The following is a description of a gene set: studied in species Mus musculus Mouse Gene Set: WP_GPCRS_ODORANT GPCRs, odorant, and this is the list of marker genes: Tas2r125, Brs3, Gpr158, Or5p76, Gpr107, Gpr108, Gpr31b, Mrgpra1, Mrgprb8, Cmklr2, Tas2r107, Gpr182, Gpr153, Vmn1r42, Or8g17, Gpr34, Vmn1r51, Taar7e, Tas2r117, Gpr87, Or10d1b, Tas1r2, Gpr139, Gpr150, Or7a40, Vmn1r48, Tas2r138, Tas2r102, Tas2r135, Vmn2r-ps54, Gpr82, Mrgprb3, Tpra1, Tas2r124, Or5p4, Opn1sw, Gpr162 (NCBI Gene Id 14788), Or9s13, Mrgprf, Taar5, Tas2r120, Gpr22, Tas2r143, Tas2r106, Mrgprb5 (NCBI Gene Id 404239), Or6b9 (NCBI Gene Id 258349), Gpr37l1, Mrgprh, Or5t17, Gpr142, Or3a10, Lgr5, Oprl1, Or7d11, Or10n1, Mrgpra4, Adgra2, Tas1r3, Gpr20, Gpr101, Gpr61, Hcar1, Or8a1b, Tas2r114, Or10p22, Rho, Gpr4, Or4b13, Vmn2r1, Gpr55, Gpr180, Or2a7, Gpr160, Or2b6, Vmn1r53, Mrgpre, Taar4, Gpr63, Or5g26, Adgrg5, Gpr152, Gpr88, Or5p79, Or1j1, Gpr27, Or5j3, Gpr171, Vmn1r47, Taar3, Gpr25, V1ra8, Gpr84, Gpr12, Cmklr1, Vmn1r45, Gpr137, Or5t15, Or5h17, Tas2r109, Taar6, Gpr37, Tas2r136, Or7e178, Gpr176, Mrgprg, Or5h19, Adgrf1, Mrgprx1, Or5m5, Gpr35, Gpr156, Mrgprb2, Tas1r1, Gpr3, Or10h28, Or5ap2, Or10d3, Gpr33, Gpr19, Gpr89, Vmn1r43, Lgr6 (leucine-rich repeat-containing G protein-coupled receptor 6), Taar2 (trace amine-associated receptor 2), Adgrg7, Tas2r129, Gpr141, Or5g9, Ptgdr2, Gpr155, Or5g25, Taar9, Or5h18, Or5t7, Or2y1b, Gpr21, Adgrd1, Gpr137c, Wls, Adgrg6, Gpr26, Adgrf3, Or5p58, Gpr161, Or5p80, Or5t9, Adgrf2, Gpr85, Or8b3, Opn1mw, Vmn1r52, Gpr173, Tas2r116, Gpr183, Mrgprb1, Tas2r139, Or5p57, Adgrf5, Or1e16, Tas2r134, Gpr146, Adgrg3, Gpr149, Gpr157, Or8b8, Tas2r113, Gpr75, Or5b21 (NCBI Gene Id 258697), Vmn1r46, Gpr165, Gpr135, Gpr83, Tas2r104, Adgrg4, Gpr137b, Adgrf4, Or4c3d, Adgra3, Or1m1, Or5ar1, Vmn1r54, Lgr4, Or2c1, Or5p52, Or8u9, Gpr179, Mrgprb4